The following is a description of a gene set: Any process that stops, prevents or reduces the frequency, rate or extent of protein catabolic process in the vacuole. Human Gene Set: GOBP_NEGATIVE_REGULATION_OF_PROTEIN_CATABOLIC_PROCESS_IN_THE_VACUOLE species: Homo sapiens, and this is the list of marker genes: ATP13A2, USP8, MGAT3, LAPTM4B, VPS35